Given this list of marker genes PLEKHH2, SLC25A53, NPR1, HDAC7, B4GALNT1, ARHGEF18, PGM2L1, PCCB, SHISA5, PAG1, HCST, ESYT2, CPM, SRPK1, NPM1, B3GNT5, ELP3, FUT11, PLAAT3, NLK, PATJ, FRMD8, DMAC1, IRF6, C15orf61, ENTPD5, UGCG, MCRIP2, KCNAB2, IGSF23, SELPLG, TWNK, COG2, KCNMB4, EOMES, GALNT7 (NCBI Gene Id 51809), GDPGP1, RALGPS2, DLEU7, LY75, DNAH8, SLC17A9, ZNF146 (NCBI Gene Id 7705), IMP3, SSBP2, SUSD1, PCSK1N, RIPOR2, ZNF354C, ACSBG1, MYC, MRPL58, SEC22C, LRFN4, MPHOSPH9, IRF2BPL, DYRK2, SRSF12, MRM3, EEIG1, SLC16A11, ABCC5, COL11A2, KDM4B, GGACT, SMAD3, TPST2, SKI, CD5 (NCBI Gene Id 921), USP24, HACD3, SMPD1, SNHG17, NT5E, HOXB6, TUBA4A, ITPKB, ACTN1, ZNF2, WASHC3, MAT2B, SELENOW, SLN, ZFP1, SLC16A6, MATN4, ZNF260, CYP46A1, KIF1B, RPL36A, BZW2, GBP7, GTF2IRD2, TUSC2, NPB, RACK1, BDH1, TTC27, SLAMF1, THNSL2, ARL4D, CBR1 (carbonyl reductase 1), ZBTB2, HARS2, SLC6A19, PDLIM1, TELO2, B3GNT2, PGK1, PIP5KL1 (phosphatidylinositol-4-phosphate 5-kinase like 1), MAN1A2, KLHL12, TEX264, ADI1, ANO10, LIPT1, SRM, H2AJ, GRAMD2B, CEP97, PSTK, WDR74, MYBPC1, SFXN4, GBP2, BACH2, BYSL, STAT4, ESYT1, CAMSAP2, ATP5F1D, KLF7, ARHGEF1, SIGIRR, KIAA1614, CCS, EMG1, ARID5A, MTFR1, ZDHHC15, TTLL12, ABHD8, METTL1, STK4, DENND4C, TCF12, C8orf58, EXOSC2, OXCT1, DNAJC15, EPHB6, GALNT10, ATIC (5-aminoimidazole-4-carboxamide ribonucleotide formyltransferase/IMP cyclohydrolase), DNAJC18, CTSE, LBP, BCDIN3D, PPM1J, SMYD3, XRCC4, PARD6G, EFEMP2 (NCBI Gene Id 30008), CCDC30, ICAM2, FAM3C, MYO7A, IZUMO1R, CCM2, UTP4, GARIN3, ZNF287, B3GALT4, TBX6, SERPINB6, FAM8A1, SLC20A1, CCR7, ANGPTL4 (NCBI Gene Id 93954), TMEM44, SLC5A6, CCR9, SIAH1, POLM, ENDOG, SDR39U1, TMEM9, DMRTA1, RANBP10 (NCBI Gene Id 57610), RAC2, PTGER2, ZBTB11-AS1, SPATA13, PHB1, PAXX, SLC11A2, ZDHHC20, AXIN2 (axin 2), TMLHE, PPP2R5A, ANKRD9, here is a description of the gene set: Human Gene Set: GSE17186_MEMORY_VS_NAIVE_BCELL_UP Genes up-regulated in B lymphocytes: memory versus naïve. Goals/objectives: to identify various gene expression in B cell subsets derived from human PBMC and cord blood from publication Suryani S, Fulcher DA, Santner-Nanan B, Nanan R, Wong M, Shaw PJ, Gibson J, Williams A, Tangye SG (PMID 19965666) studied in species Homo sapiens